The following is a description of a gene set: NTHL1 is a DNA N-glycosylase that catalyzes the first step in base excision repair (BER), the primary repair pathway for oxidative DNA damage. NTHL1 can recognize and remove oxidized cytosine, adenine and thymine, in the form of cytosine glycol (Cg), 4,6-diamino-5-formamidopyrimidine (FapyA), and thymine glycol (Tg), respectively. NTHL1 can also recognize and remove dihydrouracil (DHU), produced by cytosine deamination. Germline mutations that impair function of NTHL1 predispose affected patients to a cancer syndrome (NTHL1 syndrome) that involves adenomatous polyposis and colorectal cancer, similar to MUTYH-associated polyposis (MAP), but also causes development of tumors in other organs, such as breast, bladder, skin, uterus and brain. Only patients with mutations in both alleles of NTHL1 are affected, indicative of an autosomally recessive inheritance. Some common NTHL1 polymorphisms may results in reduced NTHL1 function, but predisposition of affected individuals to cancer has not been studied in full. Mice that are double knockout for Neil1 and Nthl1 genes accumulate DNA damage in the form of FapyA and FapyG and are more prone to development of lung adenocarcinoma than single Neil1 or Nthl1 gene knockouts. Biallelic loss-of-function mutations in NTHL1 result in a mutational signature characterized by C>T transitions at non-CpG sites. For review, please refer to Weren et al. 2018.<br>Besides loss-of-function mutations, NTHL1 is amplified and overexpressed in some cancers. NTHL1 overexpression leads to genomic instability in non-transformed human bronchial epithelial cells and may lead to malignant transformation. Reactome Pathway: Defective Base Excision Repair Associated with NTHL1 part of: Diseases of Base Excision Repair studied in species Homo sapiens, and this is the list of marker genes: NTHL1